Given this list of marker genes HCAR3, HCAR1, HCAR2, here is a description of the gene set: Reactome Pathway: Hydroxycarboxylic acid-binding receptors studied in species Homo sapiens The G-protein-coupled receptors Hydroxy-carboxylic acid receptor 1 (HCAR1, GPR81), HCAR2 (GPR109A), and HCAR3 (GPR109B) have significant sequence homology and are encoded by clustered genes. Their endogenous ligands are hydroxy-carboxylic acid metabolites. HCAR1 is activated by lactate (2-hydroxy-propanoic acid). HCAR2 is a receptor for 3-hydroxy-butyric acid. HCAR3 is activated by 3-hydroxy-octanoic acid. HCAR1 and HCAR2 are found in most mammalian species; HCA3 is found only in higher primates. All three receptors are expressed in adipocytes and are coupled to Gi-type G-proteins, mediating antilipolytic effects in fat cells. HCAR2 and HCAR3 are also expressed in a variety of immune cells. HCAR2 is a receptor for the antidyslipidemic drug nicotinic acid (niacin) and related natural and synthetic compounds. part of: Class A/1 (Rhodopsin-like receptors)